The following is a description of a gene set: from publication Kerkar SP, Goldszmid RS, Muranski P, Chinnasamy D, Yu Z, Reger RN, Leonardi AJ, Morgan RA, Wang E, Marincola FM, Trinchieri G, Rosenberg SA, Restifo NP (PMID 22056381) Myeloid-derived cells comprising the tumor stroma represent a heterogeneous population of cells critical to the structure, function and growth of established cancers. We have recently found that engineering tumor-specific CD8+ T cells to secrete IL-12 (IL-12TD) can lead to striking improvements in T-cell activity against established melanomas in murine models. Surprisingly, IL-12-dependent enhancement of CD8+ T-cell anti-tumor function did not occur through direct ligation of receptors on lymphocytes or NK cells. Instead, IL-12 sensitized host bone marrow-derived tumor-stromal cells, partly through interferon-gamma, to indirectly enhance the effects of adoptively-transferred T cells. Direct presentation of antigen by tumor was not necessary, but MHC class I expression on endogenous cells was essential for IL-12 mediated anti-tumor enhancements. Upon successful treatment with IL-12TD cells, we observed the selective elimination of tumor-infiltrating CD11b+ F4/80+ macrophages, CD11b+/ClassII+/CD11c+ dendritic cells and CD11b+/Ly6C+/Ly6G- but not CD11b+/Ly6C+/Ly6G+ myeloid-derived suppressor cells within regressing lesions. These results are consistent with a model whereby IL-12 triggers the maturation of myeloid-derived cells into competent antigen cross-presenting cells. Licensed recognition of these antigens by effector T cells may in turn trigger the collapse of the tumor stroma and aid in the regression of large vascularized lesions. species: Homo sapiens Human Gene Set: GSE29164_UNTREATED_VS_CD8_TCELL_TREATED_MELANOMA_DAY7_UP Genes up-regulated in B16 melanoma (day 7): untreated versus adoptive transfer therapy., and this is the list of marker genes: IL12RB1, PHPT1, APOE, TK2, NEDD4, CSF1R, VCAM1, MYO1F, PLIN2, ZAP70, CMTM7, ADGRG3, VKORC1, ITM2C (NCBI Gene Id 9523), WDR81, GIMAP4, S100A10, FOXO3, SEPHS2 (selenophosphate synthetase 2), DOK2, NOTCH1, RNH1, MIEN1, SYF2, SMPD1, PRF1, ICAM1, IRAG2, LMO4, PRPF31, POLR1H, UBA7, TOR2A, SIN3B, CD37, TMEM176B, SEC61A1, SFT2D1, IFI27, GPC1, TMEM176A, CDK5RAP3, KLRK1, SLC35B2, CD93, SH3D19, CD82, VARS1, NUDT1, JCHAIN, RRBP1, IL4I1, DENND4C, CSNK1G2, PIH1D1, XDH, IL18RAP, CTSH, RNPEP, ENTPD1 (NCBI Gene Id 953), TNFRSF18, GEM, CORO1B, PSME1, MMP9, FLOT1, B4GALNT1 (NCBI Gene Id 550623), PRKCSH (PRKCSH beta subunit of glucosidase II), HOPX, UNC119B, C9orf40 (NCBI Gene Id 55071), VCL, RIN2, CCL5, MAPKAPK2, DTX1, CXCR3, CYBA, ETFB, ANAPC13 (anaphase promoting complex subunit 13), SRGAP2, HHEX, INPPL1, CTSW, HPN, XBP1, MAP3K8, KLRD1, SOAT2, LDAF1, F2RL2, SPSB2 (NCBI Gene Id 84727), PPP3CA, FRG1, IL4, CCR2, BCL2A1, ANXA1, EVI2A, SELENOK, LYN, TYROBP, PLAC8, IFNG, DDHD2, NSMAF, CD44, TIRAP, ARAF, TNFRSF1B, DNAJC1, FIBP, KCNA3, CD160, FASLG, RNASE4, SIRT3, MYO6, ATP6V0B, SOD2, CASP7, CKB, ALAD, PSMB3, IFITM10, RAC2, PRKACB, NECAP2, BAX (NCBI Gene Id 581), F2R, UBXN1, DDX24, PDXK, RPP25L, AGPAT3, ZBTB16, FBXW4 (F-box and WD repeat domain containing 4), ABCF1, PEX6 (NCBI Gene Id 5190), ANTKMT, LAMTOR4, CCR5, IRF8, PADI2, ABT1, TOX4, CAMK2B, ADAM19, LY9, GLMP, ID2, BHLHE40, CLN8, SOCS2, AUP1, DGAT1, THY1, PRPSAP1, SLC25A53, ST3GAL6 (NCBI Gene Id 10402), CCR9, CPT2, PIP5K1A, PPP3CC, PXN, SLC25A28, ELL2, RGS3, BLM, SNX17, MEF2A, CXXC5, CD19 (CD19 molecule), PCGF2, EIF3B, PMM2, SLC3A2, MARCKS, FGL2, KCTD12, FUCA1 (NCBI Gene Id 2517), ALDOA, SPTLC2, CYFIP2, BZW2, EYA2, UFC1, CTSA, GZMA, PSMB8, DNAJC3, PLA2G7, TYRO3, TNK2, SLC35B1, NBEAL2, CWC15, ACOT7, HGSNAT, CTSD